Given this list of marker genes USP37, YOD1 (YOD1 deubiquitinase), VCPIP1, USP30, OTUD6A, OTUD3, TNFAIP3, OTUB2, OTUD7A, OTUD4, OTUD7B, here is a description of the gene set: Human Gene Set: GOBP_PROTEIN_K11_LINKED_DEUBIQUITINATION species: Homo sapiens A protein deubiquitination process in which a K11-linked ubiquitin chain, i.e. a polymer of ubiquitin formed by linkages between lysine residues at position 11 of the ubiquitin monomers, is removed from a protein.